Given this list of marker genes KLHL13, EBF1, CYB561A3, ZC4H2, GALP, GNB4, TRPM7, ALDH16A1, ST6GAL1, SLC2A10, SVBP, AMER1, PAK1, LCE1B, SLC25A21 (NCBI Gene Id 89874), CPM, RASAL2, AK6, MAP2, LRRC27, FNBP4, TSPEAR, FBXW7, SLC4A5, ANKRD40, ERBB4 (NCBI Gene Id 2066), TNNI1, AHCYL2, MS4A2, CDK2AP2, PHF24, DDX6, ING4, RLIM, VPS29, NCOA4, KLHDC8A, DCX, MOBP, BNC2, CHPF, ADARB2, CEP85 (NCBI Gene Id 64793), IDH1, FNDC5, SAR1A, FBXO28, BACH1, ZBTB39, EXOSC3, FCHSD2, EIF4B, NTRK2, C2CD6, AASDH (aminoadipate-semialdehyde dehydrogenase), SLC16A7, ANKS1A, MTCL2, RNF10, ZSCAN16, DOK3, MYRF (NCBI Gene Id 84755), TBL1XR1, NECAP1, LCT, LRRC8B, ELOVL5, DSCAML1, CECR2, SNTB2, FCGR1BP, PREPL, BLTP3A, HOXA4, LRP4, ENTPD7, CYSLTR2, PAX5, WDTC1, MUC3A, SYN1, KIRREL1, RAP1A, SLC17A8, RASL10B, MTMR7, GLRX, ZBTB2, QTRT2, ELOVL3, HOXA3, SCGB2B2, SRL, CLVS2, EIF4E, MAF, TMEM214, TRIM46, DAZL, DOCK3, TNFRSF21, PLEKHG2, PLAGL2, CCDC9B (NCBI Gene Id 388115), SPG7, MAP3K9, TP53I11, ANKRD52, THUMPD2, TOX3, STK32C, HNF4A, PDE4A, FBN1, INTS6, EN2, SLC38A1, SCN8A, LINC03040, OTULIN, GYPE, GAS7, RPS24, SLC26A10P, C1orf216, SMG7, DAZ1, FMNL3, PPP3R1, PER1, CELF5, ADAM12, SLC46A1, CHD4, CDH7, TBC1D7, CREB1, ADCK1, SLC36A1, FAAP20, METTL8, PAFAH2, ZFAND4, OR2H1, CDK6, ILDR2, JPH4, ARHGEF4, PPIL2, MOSMO, SYNPO2L, SDK2, GOLGA1, MAB21L4, CORO2B, PHACTR4, ASH1L, AWAT2, NT5C1B-RDH14, TBC1D25 (NCBI Gene Id 4943), OPRM1, STAU2, CD276, CREB5, FANCL, PIK3CB, BORCS7, FOXD2, AKAP13, CLTCL1, NKAIN1, ZKSCAN2, ZNF652, KCND1, AP3D1, HCFC1, TRIM66, MS4A10, ZNF22, TBC1D13, PRKCB, PAPOLB, NFIC, FAR2, NHSL3, KMT2D, SCAMP1, SHF, PABIR2, VPS26B, TAS2R14, EGR3, PRDM11, AP1G1, R3HDM2, MSN, FSTL4, FN1, PGAP4, SEPTIN6, ZKSCAN8, AAK1, VAMP1, STUM (NCBI Gene Id 91267), SCN3B, ZMAT3, RSPO4, TTC22, PHLPP2, REL, RANBP6, GRM6, MLLT3 (MLLT3 super elongation complex subunit), ITGA9, ATXN1L, OPCML, FAM131B, ASB5, FBXO46, CLCN6, RSPO3, FBXO32, DAZ3, KSR2, GJB6, SEMA4G, CHST10, PDE1C, PIM2, ABHD16A, TCF12, CEP41, GPD1, RIMS4, GPATCH2L, UBXN2B, TAFAZZIN, CDC20B, RNF19A, MAN1A2, KLHL42, RRP1B, RHO, LINC02907, RAB10, RECQL5, PRR27, SLC7A6, PRP4K, HBS1L, RFX1 (regulatory factor X1), TFAP2B, BTK, MECP2 (NCBI Gene Id 8274), SIAH3, SPRY4, EIF3J, SSBP2, SP1, DUOXA1, CD300E, PLAT, ASB11, CMTM4 (CKLF like MARVEL transmembrane domain containing 4), ACSL1, LYPD6, FUCA1, ZNF133, FBXO21, PTPN14, APOC4, PROM2, LPP, ZNF646, GIPC2, SASH1, LPXN, RIMS3, ABL2, YWHAE (NCBI Gene Id 7531), NHSL1, SPATA33, EFCAB11, CILP2 (NCBI Gene Id 148113), DNMT3B, CEP250, BTN2A1, ZBTB20, CUX1, DICER1, SPCS3, SNX27, CCBE1, KLF8 (NCBI Gene Id 11279), ING3, ZFP3, CPLX4, TMCC2, PHF8, CFAP141, ASCC1, ZFAND5, TMEM127 (transmembrane protein 127), LONRF2, TNRC6B, CSNK2A1, ZDHHC7, RTL4, F9, TXNRD1, FAM135B, AQP1, SET, ANKFY1, PALM2AKAP2, TMEM178B, OTX1, ELF2, USP18, ASTN1, GARIN2, here is a description of the gene set: from publication Chen Y, Wang X (PMID 31504780) Human Gene Set: MIR4516 species: Homo sapiens Genes predicted to be targets of miRBase v22 microRNA hsa-miR-4516 in miRDB v6.0 with MirTarget v4 prediction scores > 80 (high confidence targets).